Given this list of marker genes NFATC3, YWHAE, CSNK2A1, MEF2D, PPP3CA, BCL2, MAPK8, CSNK1A1, CABIN1, PPP3R1, FKBP8, PRKCB, FKBP1A, YWHAZ, PRKCH, KPNA2, RCAN2, CHP1, NR4A1 (nuclear receptor subfamily 4 group A member 1), PRKCA, YWHAG, CAMK4, PRKCE, AKAP5, SFN, GSK3B, BAD, KPNB1, MAPK3, NFATC1, PRKCG, MAP3K1, RCAN1, PPP3CB, EP300, PRKCZ, PRKACA, PIM1, MAPK14, NUP214, YWHAQ, MAPK9, NFATC2, PRKCQ, BCL2L1, MAP3K8, RAN, PRKCD (protein kinase C delta), CASP3, CREBBP, YWHAB, XPO1, YWHAH, here is a description of the gene set: from publication Schaefer CF, Anthony K, Krupa S, Buchoff J, Day M, Hannay T, Buetow KH (PMID 18832364) Human Gene Set: PID_NFAT_3PATHWAY species: Homo sapiens Role of Calcineurin-dependent NFAT signaling in lymphocytes